Given this list of marker genes CALCB, RAMP1, ADM2, CALCRL, RAMP2, CALCA, IAPP, RAMP3, SCN11A, ADM, CALCR, here is a description of the gene set: Human Gene Set: GOBP_CALCITONIN_FAMILY_RECEPTOR_SIGNALING_PATHWAY studied in species Homo sapiens A G protein-coupled receptor signaling pathway initiated by an extracellular member of the calcitonin family (e.g. adrenomedullin, adrenomedullin 2 (intermedin), amylin, calcitonin and calcitonin gene-related peptides (CGRPs)) binding to its receptor on the surface of a target cell, and ending with the regulation of a downstream cellular process.